The following is a description of a gene set: A multiprotein complex containing a heterodimeric E2F transcription factor and a Retinoblastoma (Rb) family member. This complex is capable of repressing transcription of E2F-regulated genes in order to regulate cell cycle progression. Mouse Gene Set: GOCC_RB_E2F_COMPLEX studied in species Mus musculus, and this is the list of marker genes: E2f1, Tfdp1, Cebpa, Rb1, E2f2